Given this list of marker genes Slc43a3, Aqp9, Slc28a2, Slc28a1, Slc29a2, Slc29a1, Slc28a3, Slc28a2b, Slc29a3, here is a description of the gene set: studied in species Mus musculus Mouse Gene Set: GOMF_NUCLEOBASE_TRANSMEMBRANE_TRANSPORTER_ACTIVITY Enables the transfer of a nucleobase, any nitrogenous base that is a constituent of a nucleoside, nucleotide, or nucleic acidfrom one side of a membrane to the other.